The following is a description of a gene set: Human Gene Set: HP_HIRSUTISM species: Homo sapiens Abnormally increased hair growth referring to a male pattern of body hair (androgenic hair). Hirsutism, and this is the list of marker genes: MAP3K1, ATRX, PPP1R21, ERCC6, TRIM32, GJA1, TBX15, BMP15, GJB3 (gap junction protein beta 3), OTUD5, GLB1, MAP1B, AIMP2, CEP19, SMO, ADAMTS2, TAF1, RAB18, FUT8, ASXL3, BBS4, GLI3, MKS1, LZTFL1, RPL10, CYP11B1, EMC10, SOX4, SLC25A24, LMNB2, SMARCD1 (SWI/SNF related, matrix associated, actin dependent regulator of chromatin, subfamily d, member 1), IPO8, USP48, CFAP418, CAPN15 (NCBI Gene Id 6650), H6PD, BRAF, WDR26, ELMO2, SCLT1, HGSNAT, TBCK, TBCD (NCBI Gene Id 6904), BBS2, PUM1, PRMT7, IRF6, IFT172 (intraflagellar transport 172), NANS (NCBI Gene Id 54187), TTC5, CNP, CACNA1G, MAP3K7, DLK1, POLR3A, SUCLA2, KMT2A, MKKS, KCNH1, ARMC5, PLAAT3, KDM6A, AIP, SOX6, SGSH, SMARCA4 (NCBI Gene Id 6597), CAV1, POR, USP8, UFC1, LRPPRC, SHROOM4, FBXO11, CCBE1 (collagen and calcium binding EGF domains 1), CAVIN1, RERE, RAD21, SMARCD2, BBS7, BCL11B, FRMD4A, HIVEP2, TBC1D20, CEP290, CASZ1, BBS9, TWIST1, TWIST2, BBIP1, PEPD, MGAT2, AGPAT2, IFT27, SKI (SKI proto-oncogene), CNOT2, CTSC, WDPCP, BMP1, VPS33A, BRD4, KDM1A, MMP2, GNB2, RTL1, ARID2, ASXL1, SETD2, MBD5, MAB21L1, RAB3GAP2, ABCA5, LUZP1, CDH23, RECQL (RecQ like helicase), SETBP1, FSHR, GJB4, BBS5, SMARCC2, MAPK1, SLC25A12, OFD1 (NCBI Gene Id 8481), SCAPER, AKT1, HSPG2, LMNA, TOE1, ARL6, MAPRE2, BBS1, KDSR, RIN2, GNAS, PLAA, ABCC9, NPHP1, TP53, TTC8, IDUA, MMP23B, NAGLU, SMARCB1, TP63, PRKAR1A, SMC3, MMP14, PRDM16, ADNP, GPR101, GABRD, PRKCZ, WAC, HNRNPR, XYLT1, EP300, GNS, PRKACA, NR3C1, IFT74, NFIX, AFF4, ARID1A, ATP6V1B2, PRKG2, CREBBP, FLNA, SMC1A, WNT4, PAPSS2, KMT2D, HDAC8, CDK5, ARX, KCNJ8, PPARG, MOGS, COPB1, NOTCH2, WASHC4, BBS12, NKX6-2, GNE, PDE11A, FGFR2, DPF2, CYP19A1, SOX11 (NCBI Gene Id 6664), NIPBL, EIF4A2, BSCL2, ARID1B, TRIO, TUBB, SDCCAG8, UBE2A, SRCAP, RAB3GAP1, TAF6, KCNAB2, INSR, HSD3B2, SPEN, PDPN, UBE4B, ALMS1, TASP1, ARSB, MEG3, SMARCE1, CKAP2L, CCDC28B, BBS10, CPOX, GUSB, WDR81